Given this list of marker genes Polr1g, Polr2l, Ddx21, Polr1h, Ep300, Polr1c, Taf1d, Tbp, Mybbp1a, Ercc6, Polr2k, Polr2f, Smarca5, Polr2e, Polr1e, here is a description of the gene set: Reactome Pathway: Positive epigenetic regulation of rRNA expression part of: Epigenetic regulation of gene expression studied in species Mus musculus This event has been computationally inferred from an event that has been demonstrated in another species.<p>The inference is based on the homology mapping from PANTHER. Briefly, reactions for which all involved PhysicalEntities (in input, output and catalyst) have a mapped orthologue/paralogue (for complexes at least 75% of components must have a mapping) are inferred to the other species. electronically inferred by orthology from the curated human pathway